The following is a description of a gene set: Any process that stops, prevents, or reduces the frequency, rate or extent of the neurotrophin TRK receptor signaling pathway. studied in species Mus musculus Mouse Gene Set: GOBP_NEGATIVE_REGULATION_OF_NEUROTROPHIN_TRK_RECEPTOR_SIGNALING_PATHWAY, and this is the list of marker genes: Ptprf, Spry2, Agt, Spry1, Agtr2